Given this list of marker genes ST3GAL3, FURIN, ST3GAL4, MAN1B1, FUT8, MAN2A1, MGAT4C, ST6GALNAC4, CANX, ST6GALNAC3, ST6GAL1, PARP16, ST6GALNAC2, MGAT4A, MGAT4B, PRMT1, ST3GAL2, MGAT1, SPCS3, PARP10, CSNK1A1, MGAT2, MOGS, GSK3B, EDEM2, MGAT5, SPCS1, GSK3A, ST3GAL1, GALNT1, PARP9, here is a description of the gene set: studied in species Homo sapiens Human Gene Set: GOBP_VIRAL_PROTEIN_PROCESSING Any protein maturation process achieved by the cleavage of a peptide bond or bonds within a viral protein.